Given this list of marker genes Trdmt1, Trmt9b, Trmt44, Wdr4, Alkbh8, Mettl1, Bcdin3d, Wdr6 (NCBI Gene Id 83669, WD repeat domain 6), Nsun2, Lcmt2, Thada, Mto1, Gtpbp3, Tarbp1, Ftsj1, Trmt10c, Trmt10b, Thumpd3, Thumpd2, Trmt61a, Nsun4, Trmt1l, Trmo, Trmt6, Trmt1, Trmt10a (tRNA methyltransferase 10A), Hsd17b10, Mettl8, Trmt12, Dalrd3, Nsun3, Akt1 (thymoma viral proto-oncogene 1), Tyw3, Trmt13, Mettl2, Trmt5, Mettl6, Trmt112, Nsun6, here is a description of the gene set: The posttranscriptional addition of methyl groups to specific residues in a tRNA molecule. Mouse Gene Set: GOBP_TRNA_METHYLATION studied in species Mus musculus